Given this list of marker genes MYO7A, PTPRN, GBP1, EPB41, ADD2, SPTBN5 (NCBI Gene Id 51332), DYNC1I1, ADD1, ANK1, ANK2 (NCBI Gene Id 4028), PTPRC, PDE6G, EPB41L2, ANK3, CAMSAP3, USH1C, CAMSAP2, DMTN, SAG, KIF3A, USH1G, MYO10, CAMSAP1, DCTN2, GNB3, SLC26A5, SPTBN4, here is a description of the gene set: species: Homo sapiens Binding to spectrin, a protein that is the major constituent of the erythrocyte cytoskeletal network. It associates with band 4.1 (see band protein) and actin to form the cytoskeletal superstructure of the erythrocyte plasma membrane. It is composed of nonhomologous chains, alpha and beta, which aggregate side-to-side in an antiparallel fashion to form dimers, tetramers, and higher polymers. Human Gene Set: GOMF_SPECTRIN_BINDING